Given this list of marker genes Fasl, Map6, Med14, Itgb2, Gnai1, 4632404M16Rik, Insm2, Hyal3, Cpne8, Itih3, Mapk14, Skap2, Fgf12, Rab32, Gimap7, Mmp1a, Adora2b (adenosine A2b receptor), Add1, Edil3, H1f2, Serpina3k, Nab1, Flt3l, Pcyt1a, Rad51ap1, Tnfsf8, Lyn, Msc, Cast, Arhgap20, Eps15, here is a description of the gene set: Bexarotene (Targretin), is a synthetic high-affinity RXR receptor agonist with limited affinity for RAR receptors. Bexarotene has shown efficacy in a phase I/II trial of non-small-cell lung cancers. However, the chemopreventive efficacy of bexarotene has not been determined in mouse lung cancer models. In this study, we have investigated the ability of bexarotene to inhibit lung tumor progression in the mutant A/J mouse models with genetic alterations in p53 or K-ras, two of the most commonly altered genes in human lung tumorigenesis. Mice were administered vinyl carbamate (VC), a carcinogen, by a single intraperitoneal injection (i.p.) at 6 weeks of age. Bexarotene was given by gavage starting at 16 weeks after VC and was continued for 12 weeks. Although all mice developed lung tumors, only 7% of lung tumors were adenocarcinomas in wild-type mice, whereas 22 and 26% of lung tumors were adenocarcinomas in p53 transgenic or K-ras heterozygous deficient mice. Bexarotene inhibited both tumor multiplicity and tumor volume in mice of all three genotypes. Furthermore, bexarotene reduced the progression of adenoma to adenocarcinoma by approximately 50% in both p53(wt/wt)K-ras(ko/wt) and p53(wt/wt)K-ras(wt/wt) mice. Thus, bexarotene appears to be an effective preventive agent against lung tumor growth and progression. from publication Wang Y, Zhang Z, Yao R, Jia D, Wang D, Lubet RA, You M (PMID 16247446) Genes down-regulated in the mouse lung cancer model and which reverted to normal levels upon treatment with bexarotene. studied in species Mus musculus Mouse Gene Set: WANG_RESPONSE_TO_BEXAROTENE_DN